Given this list of marker genes Ube4a, Ube4b (NCBI Gene Id 80643), Ubr5, Prpf19, Itch, Stub1, Rbx1 (NCBI Gene Id 80401), Ube2k, Peli1, Ubox5, Traf6, Amfr, Ppil2, Anapc11, here is a description of the gene set: Mouse Gene Set: GOMF_UBIQUITIN_UBIQUITIN_LIGASE_ACTIVITY species: Mus musculus Isoenergetic transfer of ubiquitin from one protein to an existing ubiquitin chain via the reaction X-ubiquitin + Y-ubiquitin = Y-ubiquitin-ubiquitin + X, where both the X-ubiquitin and Y-ubiquitin-ubiquitin linkages are thioester bonds between the C-terminal glycine of ubiquitin and a sulfhydryl side group of a cysteine residue.